The following is a description of a gene set: species: Mus musculus from publication Cui A, Huang T, Li S, Ma A, Pérez JL, Sander C, Keskin DB, Wu CJ, Fraenkel E, Hacohen N (PMID 38057668) Mouse Gene Set: CUI_PDC_IL7_RESPONSE_UP Genes positively differentially expressed in cell type: pDC (plasmacytoid dendritic cell) upon treatment with cytokine: IL-7 in mouse lymph nodes in vivo. Cytokines mediate cell-cell communication in the immune system and represent important therapeutic targets. A myriad of studies have highlighted their central role in immune function, yet we lack a global view of the cellular responses of each immune cell type to each cytokine. To address this gap, the authors created the Immune Dictionary, a compendium of single-cell transcriptomic profiles of more than 17 immune cell types in response to each of 86 cytokines (>1,400 cytokine-cell type combinations) in mouse lymph nodes in vivo. A cytokine-centric view of the dictionary revealed that most cytokines induce highly cell-type-specific responses. For example, the inflammatory cytokine interleukin-1β induces distinct gene programmes in almost every cell type. A cell-type-centric view of the dictionary identified more than 66 cytokine-driven cellular polarization states across immune cell types, including previously uncharacterized states such as an interleukin-18-induced polyfunctional natural killer cell state., and this is the list of marker genes: Ccnd2, Ccnd3, Cd72, Actg1, Pfn1, Sdc4, Napsa, Hmgcs1, Ccnd1, Gpx1, Socs3, Selplg